The following is a description of a gene set: 2q21.1 copy number variation syndrome Human Gene Set: WP_2Q211_COPY_NUMBER_VARIATION_SYNDROME studied in species Homo sapiens, and this is the list of marker genes: FAM168B (family with sequence similarity 168 member B), LINC01087, POTEE, RHOA, PLEKHB2, CCDC42, GPR148, MIR4784, STMN2, MZT2A, APC, TUBA3D, STAT3, ARHGEF4, RAC1, CDC27, AMER3, CCDC74A